The following is a description of a gene set: from publication Lin JX, Li P, Liu D, Jin HT, He J, Ata Ur Rasheed M, Rochman Y, Wang L, Cui K, Liu C, Kelsall BL, Ahmed R, Leonard WJ (PMID 22520852) studied in species Homo sapiens Cytokine-activated STAT proteins dimerize and bind to high-affinity motifs, and N-terminal domain-mediated oligomerization of dimers allows tetramer formation and binding to low-affinity tandem motifs, but the functions of dimers versus tetramers are unknown. We generated Stat5a and Stat5b double knock-in (DKI) N-domain mutant mice that form dimers but not tetramers, identified cytokine-regulated genes whose expression required STAT5 tetramers, and defined consensus motifs for dimers versus tetramers. Whereas Stat5- deficient mice exhibited perinatal lethality, DKI mice were viable, indicating that STAT5 dimers were sufficient for survival. Nevertheless, STAT5 DKI mice had fewer CD4+CD25+ T cells, NK cells, and CD8+ T cells, with impaired cytokine-induced proliferation and homeostatic proliferation of CD8+ T cells. DKI CD8+ T cell proliferation following viral infection was diminished and DKI Treg cells did not efficiently control colitis. Thus, tetramerization of STAT5 is dispensable for survival but is critical for cytokine responses and normal immune function. Human Gene Set: GSE36888_STAT5_AB_KNOCKIN_VS_WT_TCELL_IL2_TREATED_17H_DN Genes down-regulated in T cells stimulated by IL2 for 17h: STAT5 double knock-in versus wildtype., and this is the list of marker genes: TMEM91, MPO, IKBKE, PLPPR2, GBP2, PPIP5K2, ANO10, TMEM71, TMEM205, ITCH, CLTCL1, EIF1AY, ZDHHC20, CLIC4, FTH1, MDM2, CARS2, NLRP3 (NLR family pyrin domain containing 3), AGTRAP, FMO5, TSPO, DOK3, TLR4, PRNP, CTSD, FRS2 (fibroblast growth factor receptor substrate 2, NCBI Gene Id 10818), EVI2A, LRPAP1, ST20-AS1, UPP1, CARD16, METTL9, RBP7, OGFRL1, SLC49A4, BLOC1S3 (biogenesis of lysosomal organelles complex 1 subunit 3), GRINA, ADAM9, SGMS2, DUSP6, AP1S2 (NCBI Gene Id 8905), TNFRSF1A, SHISA5, MMGT1, SRA1, TYROBP, AGTPBP1, SLC31A2, CPEB4, CHST15, FCGR2A, FCN1 (NCBI Gene Id 2219), ZNF226, CATSPER1 (cation channel sperm associated 1), LDLRAD3, PRKAA1, NTSR1, USP15, SNX24, UBE2D1, RRP12, ACSL1, SMPDL3A, NATD1, EGR2, HVCN1, SERPINB1, MSRB1, ATP1B3, GNG10, CFD, FPR2, FAM241A, ARHGAP29, NEK7, RHOT1, KPTN, ZBTB7A, AZI2, EDEM3, EGR3, B3GNT5, IPO8, DPYD, CCL8, VPS37B, SERPINA1, PAK2, NCOA1, SOD2, FRY, SLC43A3, LIN7A, SPG21, AP5B1, ACTN1, SLC38A7, LAMP1, KL, ELL2, NLRP12, TCF7L2, STK32B, HORMAD1, CLEC5A, MTMR3, GALC, NARS1, NCF1C, ANO5, KIF23-AS1, CRADD, CR1, BACH1, PLD1, ARHGEF10L, RHOQ, SPART, GASK1B, ACVR1, RXFP2, XBP1, MICU1, SEMA3C, ARID3A, KIF13A, USP8, ITPR2, ASAH1, ATXN1, SFN, TMEM106B, PYGL, CMTM2, EREG, PDLIM7, KCNE1, MBTPS1, FMR1 (NCBI Gene Id 5421), TMEM33, INPP5A, F5, GCHFR, CPD, RIOK3, SCPEP1, CD36, MIGA1, RSF1, CCPG1, UXS1, ATP6V1G1, HSPA1A, PDXK, LINC00968, ITGB1, TLR8, SEC23B, LAPTM4A, GRB10, GCA, ARL8B, EVI2B, KIAA0232, NHS, BLVRA, ITGAM, TOX2, WASHC4, SP1, MAP4K4, GPX1, ING3, HLX, PINK1, ARL15, PTGS2, SLC48A1, MTX1, EVI5, TPCN2, GPBAR1, TBC1D2, KRT23, FUCA1, ARL11, FYB1, CLIP1, FGFR1OP2, PLXDC2, TLE4, SHKBP1, IRAK3, PSRC1, NQO1, SIPA1L1, AP1M1